The following is a description of a gene set: studied in species Mus musculus COPI-dependent Golgi-to-ER retrograde traffic Mouse Gene Set: REACTOME_COPI_DEPENDENT_GOLGI_TO_ER_RETROGRADE_TRAFFIC, and this is the list of marker genes: Kif3a, Arcn1, Klc2, Use1, Kif2a, Tmed3, Kif26a (kinesin family member 26A), Arf5, Kdelr3, Kif16b, Kif26b, Kif5b, Kif23, Kif3b, Kifc5b, Copg1, Stx18, Kif18a, Copb1, Tuba8, Copb2, Kif21a, Tuba3a, Kif13b, Tubb1, Rint1, Tuba1a, Gbf1, Copg2, Kif5a, Kifc1, Kif1c (kinesin family member 1C), Rab1b, Tubal3, Tubb3, Kif4, Kif9, Kifap3, Bnip1, Kif27, Zw10 (NCBI Gene Id 76189), Tubb6, Kif3c, Cope, Tmed9, Kif1b, Napa, Copz2, Klc3, Kdelr1, Tubb2a, Kif19a, Kif20a, Nsf, Arf1, Klc4, Rab1a, Racgap1, Kif2c, Klc1, Tuba4a, Kifc2, Copz1 (coatomer protein complex, subunit zeta 1), Arf3, Napb, Napg, Kdelr2, Kif1a, Arfgap2, Kif12, Tuba3b, Cenpe, Tuba1b, Kif2b, Sec22b (NCBI Gene Id 99656), Kif22, Arfgap1, Tmed10, Kif6, Arf4, Tmed7, Kif18b, Tmed2, Tubb2b, Nbas, Kif20b, Arfgap3 (NCBI Gene Id 75390), Tuba1c, Tubb4a, Kif28, Copa, Kif21b, Surf4, Tubb4b, Kif11, Kif15